The following is a description of a gene set: Human Gene Set: GOBP_GLUCOSYLCERAMIDE_METABOLIC_PROCESS species: Homo sapiens The chemical reactions and pathways involving glucosylceramides, any compound formed by the replacement of the glycosidic hydroxyl group of a cyclic form of glucose by a ceramide group. They are neutral glycolipids containing equimolar amounts of fatty acid, glucose, and sphingosine or a sphingosine derivative., and this is the list of marker genes: GBA3, PRKCD, GBA2, MIR16-1, MIR127, FA2H, MIR195, SCARB2, UGCG, PRKAA1, GBA1